Given this list of marker genes Dhcr24, Dhcr7, here is a description of the gene set: Reactome Pathway: Cholesterol biosynthesis from zymosterol (modified Kandutsch-Russell pathway) studied in species Mus musculus electronically inferred by orthology from the curated human pathway This event has been computationally inferred from an event that has been demonstrated in another species.<p>The inference is based on the homology mapping from PANTHER. Briefly, reactions for which all involved PhysicalEntities (in input, output and catalyst) have a mapped orthologue/paralogue (for complexes at least 75% of components must have a mapping) are inferred to the other species. part of: Cholesterol biosynthesis